The following is a description of a gene set: from publication Cui A, Huang T, Li S, Ma A, Pérez JL, Sander C, Keskin DB, Wu CJ, Fraenkel E, Hacohen N (PMID 38057668) Genes negatively differentially expressed in cell type: pDC (plasmacytoid dendritic cell) upon treatment with cytokine: IL-36α in mouse lymph nodes in vivo. studied in species Mus musculus Mouse Gene Set: CUI_PDC_IL36A_RESPONSE_DN Cytokines mediate cell-cell communication in the immune system and represent important therapeutic targets. A myriad of studies have highlighted their central role in immune function, yet we lack a global view of the cellular responses of each immune cell type to each cytokine. To address this gap, the authors created the Immune Dictionary, a compendium of single-cell transcriptomic profiles of more than 17 immune cell types in response to each of 86 cytokines (>1,400 cytokine-cell type combinations) in mouse lymph nodes in vivo. A cytokine-centric view of the dictionary revealed that most cytokines induce highly cell-type-specific responses. For example, the inflammatory cytokine interleukin-1β induces distinct gene programmes in almost every cell type. A cell-type-centric view of the dictionary identified more than 66 cytokine-driven cellular polarization states across immune cell types, including previously uncharacterized states such as an interleukin-18-induced polyfunctional natural killer cell state., and this is the list of marker genes: Cat, Alox5ap, Bscl2, Ogt, Irf8, Gngt2, Tecr, Timp2, Eef1b2, Atraid, Pacsin1, Smim14, Vsir, Mxd4, Man2a2, Tnrc6b, Dap, Zeb2, Eef1g, Pkig, Psap, S100a10, Spns3, Ech1, Zfp36l1, Rack1, Arl5c, Cd28, Pafah1b3, Trappc5 (trafficking protein particle complex 5), Eif3h, Tex261, Atp2a1, Cox6a2 (cytochrome c oxidase subunit 6A2), Serinc5, Oaz1, Cd209d, Bnip3l, Adk, Pnck, Eif3f, Ypel3, Syf2, Tmem59 (transmembrane protein 59), Bin1, Tsc22d1, Smc6, Ptpn18 (protein tyrosine phosphatase, non-receptor type 18), Itgb7, Tspan13, Ramp1, Ctsl, Gnas, Gmfg, Cd209a, Tpd52, Macroh2a1, Mrpl34, Bst2, Siglecg, Acsl1, Clec10a, Siglech, Inpp5k, Snx29, Clic1, Clec12a, Selenoh, Ppfia4, Eef2, Ccr2, Khk, Zbtb20, Jakmip1, Lamtor2, Pfdn5, R3hdm4, Tyrobp, Klrd1, Rpgrip1, Runx2, Ndufa6, Aig1, Cdip1, Ptma, Sys1, Use1, Selenot, Naca, Fau (NCBI Gene Id 14109), Atp5mc2, Ripor2 (RHO family interacting cell polarization regulator 2), Trf, Uqcrh, Cd7, Dctpp1, Mef2c, Abhd17a, Erp29, Ctsb, Kmo, Sell, Tmem50a, Grina, Ptprs, Calcoco1 (calcium binding and coiled coil domain 1), Ccr5, Kctd12, Lamtor4, Pold4, Lat2, Ikzf1, Upb1, Fth1, Eef1d, Eef1a1, Serinc3, Tcf12, Oxct1 (NCBI Gene Id 67041), Mbnl1, Pabpc1 (NCBI Gene Id 18458), Mvb12a, Prdx2, Btg2, Klf2, Fyb1, Eif3e, Cox7a2l (NCBI Gene Id 20463), Macf1, Nop53, Cmah, Atp1b1, Cacna1e, Csk, Rgs10, Irf2bp2, Sptssa, Smim5, Fyn